The following is a description of a gene set: The chemical reactions and pathways involving rRNA, ribosomal RNA, a structural constituent of ribosomes. Human Gene Set: GOBP_RRNA_METABOLIC_PROCESS species: Homo sapiens, and this is the list of marker genes: NSUN5, SLX9, SLFN13, DDX49, XRN2 (NCBI Gene Id 22803), POLR1E, DDX10, UTP15, WDR43, YBEY, MYG1, MRM1, POLR2E, NIFK, RRP1B, PPAN, GTF2H5, METTL25B, GTF3C5, UTP6, TRMT2B, GEMIN4, TRIR, NGDN, FCF1, ESF1 (NCBI Gene Id 55639), POP5, PELP1, DIS3, RPP40, NOLC1, ERN2, UTP3, TAF1B, METTL18, GTF3C3, MAPT, SRFBP1, FDXACB1, NAT10, GTF3C4, RRP36, DCAF13, GTPBP4, UTP20, RPS6, RPP25, SLFN12, PRKDC (NCBI Gene Id 5591), NOL9, REXO1L1P, FBLL1, EMG1, NOL8, MRM3, BMS1 (BMS1 ribosome biogenesis factor), REXO5, TCOF1, POP7, DDX21 (NCBI Gene Id 9188), NOL10, BRIX1 (biogenesis of ribosomes BRX1), XRN1, ABT1, RPL7A, DEDD2, NPM3, SIRT7 (NCBI Gene Id 51547), RRS1, AK6, RPS7, GTF3C6, MRTO4, RPF1 (ribosome production factor 1 homolog), ZNHIT6, METTL15, KRR1, NOP9, RIOK2, EXOSC6, NOP2, UTP25, SART1, NSA2 (NCBI Gene Id 10412), DDX11, MACROH2A2, DHX37 (NCBI Gene Id 84742), NOL6, PAK1IP1, RPL11, RPS19 (NCBI Gene Id 8378), SMARCB1, RCL1, MRM2, NOC4L, RPL7L1, TRMT61B, EXOSC4, TFB2M, POLR1F, WDR3, CAVIN1, RPL35, POP4, NUDT16, SDE2, TENT4B, RPUSD4, RRP7BP, POLR1G, BRF1, IMP3, PIH1D2, EXOSC9, METTL5, TSR1, RBM34, KRI1, MTREX, DROSHA, TSR3, UTP4, DKC1, RPS8, SPOUT1, UTP23, RPL5, RPS15, RPP30, UTP14A, SUV39H1, WBP11, PIH1D1, RPS27, RPL35A, DDX18, EXOSC2, RIOK3, ERCC2, NOL11, NSUN4, METTL16, FRG1, USP36, POLR1B, PELO, TBL3, DDX51, NOP53, POLR1D, MTERF4, PWP1, DDX27, NVL, RBFA, RIOK1, NOP56, DDX56, RPP38, EXOSC8, MPHOSPH10, MPHOSPH6, METTL15P1, MACROH2A1, REXO4, RRP7A, C1D, ANG, ISG20 (interferon stimulated exonuclease gene 20), ERCC6, RPS14, DDX47, IPPK, NCL, RPS24, YTHDF2, ZNHIT3, DDX54, WDR55, BOP1, DIMT1, BUD23 (NCBI Gene Id 84118), EBNA1BP2, RPS21, NOP58, EXOSC3, RPS25, HEATR1 (NCBI Gene Id 55127), EXOSC7, URB1, WDR75, RPS17, DDX17, RPL14, RPF2, PES1, RPL27, EIF4A3, PA2G4, NHP2, RPUSD1, CDKN2A, RRP1, DEDD, RRP15, NOL7, SLFN14, EXOSC10, WDR36, RPL26, IMP4, WDR12, MYC, WDR18, RRP9, PWP2 (PWP2 small subunit processome component), EXOSC5, LAS1L, KAT2B, RPS16, RPL7, TSR2, EIF6 (eukaryotic translation initiation factor 6), SPIN1, FTSJ3, UTP14C, NOP10, SMARCA4, RPUSD2, TOP1, NAF1, WDR74, MTOR, LSM6, UTP18, EXOSC1, LYAR, GTF3A, NSUN3, NOB1, NOP14, UTP11 (NCBI Gene Id 51118), DDX52, REXO1, MARS1, CHD7, WDR46, RPS28, GTF3C1, TFB1M, ERI1, GTF3C2, FBL, ZCCHC4, BYSL (bystin like), RNASEL, MAK16, PIN4, PDCD11, TP53, GAR1, SBDS, DIS3L, SNU13, TRMT112, RRP8